Given this list of marker genes Smarcd3, Wnt11, Foxh1, Rbpj, Lrp2, Mef2c, Axin2, Isl1, Bmp4, Mesp1, Wnt5a, here is a description of the gene set: Mouse Gene Set: GOBP_SECONDARY_HEART_FIELD_SPECIFICATION studied in species Mus musculus The process that results in the delineation of a specific region of the lateral mesoderm into the area which will form the majority of the mesodermal component of the right ventricle, arterial pole (outflow tract) and venous pole (inflow tract).